Given this list of marker genes ATP13A2, ATXN1, AASS, PLA2G6, MUSK, NEK9, KCNC3, NKX6-2, POLG, FTL, TWNK, AGTPBP1, VPS13A, DLAT, ACBD6, here is a description of the gene set: Upgaze palsy species: Homo sapiens A limitation of the ability to direct one's gaze above the horizontal meridian. Human Gene Set: HP_UPGAZE_PALSY